The following is a description of a gene set: from publication Chen Y, Wang X (PMID 31504780) species: Mus musculus Genes predicted to be targets of miRBase v22 microRNA mmu_miR_706 in miRDB v6.0 with MirTarget v4 prediction scores > 80 (high confidence targets). Mouse Gene Set: MIR_706, and this is the list of marker genes: Ptpn18, Sema3d, Kcnmb2, Prex2, Wnt9b, Mospd2, Gm5592, Ppp1r18, Mboat1, Cdip1, Zmat4, Rab40b, Pcsk5, Gnaq, Il6ra, Pias2, Nrcam, Rab10, Nudt21, Cxcl14, Mysm1, Spag9, Sbspon, Casp2, Map3k9, Mylk4, Mfap1a, Kics2, Sgip1, Igdcc4, Golga1, Syne2, Slc8a1, Psenen, Piwil1, Rtkn2, Lhfpl2, Clasp2, Ptgs1, Kcnd2, Thoc2, Nav1, Tent4b, Efcab14, Plppr1, Zkscan8, Med1, Asxl3, Cmklr2, Tmem154, Scn1a, Map3k12, Atxn10, Gabrb2, Copb1, Rrad, Polr2k, Tanc2, Enah, Basp1, Meioc, Nmnat2, Cntn5, Cacna1b (NCBI Gene Id 99436), Fam135a, Foxm1, Rock1, Pabpc4, Bmpr2, Rfx7, Ackr3, Grk5, Ccdc50, Pde4b, Elac1, Brd8dc, Tia1, Mrpl44, Cyc1, Acvr2b, Bcas1, Pwwp2a, St8sia1, Tmed8, Lcorl, Med14, Mettl14, B3gnt7, Appl1, Tnrc6b, Atxn7l3b, Parpbp, Fbxo34, Kl, Shisa2, Ajuba, Nr4a2, D130043K22Rik, Pik3r1, Cdca4, Zfp455, Cdkn1b, Marchf8, Pno1, Creb5, Tomm22, Dlg2, Kif14 (kinesin family member 14), Ids, Camsap1 (NCBI Gene Id 96963), Scaf11, Syce3 (NCBI Gene Id 75459), Atf7, Rbm27, Shoc2, Slc7a14, Clec2e, Cyp21a1, Gm11837, Pkdrej, Dsg4, Gdap2, Sfpq, Taf4, Atp5mc1, Zc3h11a, Aak1, Atp6v1a, Cacul1, Or5m3b, Tfam, Sv2c, Vgll3, Tatdn1, Csnk1g2, Ado (2-aminoethanethiol dioxygenase), Clmn, Clns1a, Fzd3, Cnot4, Aff3 (AF4/FMR2 family, member 3), Nlrp9a, Lyrm9, Thumpd1, Arl13a, Ccdc88a, Kcnb1, Fsd1l, Mrfap1, Ttll11, Slc47a1, Dr1, Txndc5, Htra3, Meis1, Snap29, Sh3pxd2a, Commd8, Pus10, Phtf2, Tmem45a, Tlnrd1, Rpn2, Sphkap, Zhx3, Grm1, Sowahc, Tnfrsf11b, Polr2g, Hnrnpf, Atp1b4, Hook3, Nova1, Arfgef1 (ADP ribosylation factor guanine nucleotide exchange factor 1), Tlcd4, Cep120, Arl5a, Caap1, Usp31, Ccnyl1, Nrxn1, Homer1, Mafb, Sf3b1, Plppr5, Rap2c, Cbl, Rpgr, Serpinb7, Ephb1, Bach2, Uvrag, Fmn2 (formin 2), Zbtb14, Nceh1, Evi5, Gm4925, Gpc4, Tardbp, Stxbp6, Zranb2, Slf2, Mef2c, Mfap1b, Pakap, Ino80d, Mme, Gpr155, Drd1, Fbxl7, Tgoln1, Fam53c